Given this list of marker genes Tmem169, Marchf8, Ankrd33b, Plekha5, Ankra2, Naga (NCBI Gene Id 17939), Slc24a3, Cep170, Tmem86a, Fam91a1, Atrnl1, Gm4861, Srsf1, Lalba, Zfp189, Nxt2, Zfp738, Ints8, Rnf135, Asph, Fut1, Gpr83, Btg1, Fbxl17, Prkar1a, Osbpl7, Eif5b, Fam227a, Cdk19, Ankrd16, Socs7, Basp1, here is a description of the gene set: from publication Chen Y, Wang X (PMID 31504780) species: Mus musculus Genes predicted to be targets of miRBase v22 microRNA mmu_miR_6923_3p in miRDB v6.0 with MirTarget v4 prediction scores > 80 (high confidence targets). Mouse Gene Set: MIR_6923_3P